Given this list of marker genes PLBD1, GPS1, MGAM (NCBI Gene Id 8972), BMPER, PGBD1, MYO16 (NCBI Gene Id 23026), PPP2R3A, KRTAP9-9, SIRT1, TNFSF12, SIPA1L2, PKHD1, ABCB5 (ATP binding cassette subfamily B member 5), MMP13, ARMC3, KRTAP3-3, MAGEH1, DCLK3 (NCBI Gene Id 85443), CRLF2, SETD5, PBDC1, SMCP, CDY2B, ANK2, SLC35F2, OR2F2, CRTC1, GNG2, CEP126, SEMA6D, CIMAP3, SCGB1C1, CIMAP1A, IRF2, MITF, FAM170A, ABCA13, NRXN3, WDR64, TMEM108, KRT20, RPE65 (NCBI Gene Id 6121), RFNG, RGS7BP, SPATA6, MINDY3, ARHGAP18, LRRN1, FOXN2, CYP2E1, ORAI2, CA1, FRMPD2, CALCR, CDY1, NSMF, RIT2, KCNK2, HERC2P9, SERPINB4, TRPM2, SNHG17, CCDC54, OR2F1, LIMCH1, ZPLD1, VCAN, ANGPTL5, CLNK, MS4A3, AMOTL1, SERPINB3, UPK1B, RARA, FAT3, CAPN13, LINC00907, RPL13AP17, DNASE2B, NRAP, POU6F2, SULT1C2, MAB21L4, CLIC1, ZDBF2, CDY1B, KLHL2, FYB1, CPQ, LPAR3, ELOVL7, RPL35P1, MEP1A, KRTAP13-1, ENOX1, OR6W1P, MLF1, NCALD, LINC03122, TNFSF12-TNFSF13, GALNT5, GTF3C2, AK5, OTULINL, HERC2P2, SPRR1A, KRTAP9-3, SAPCD1, PRB3, THEMIS, CLRN1, CACNB2, TNFSF13, MSH5 (NCBI Gene Id 4439), TMEM192, MME, TLR2, NAP1L2, LINC00994, INTU, EVA1C, NOVA1, IGSF11, LINC00305, CDY2A, KRT10, SLC9C1, ZC2HC1A, NEB, LTC4S, B3GNT2, IPCEF1, KCNMB2, LAMB4, VWDE, MAML2, EBF4, here is a description of the gene set: There is widespread interest in efficient characterization of differences between tumor and normal samples. Here, we show an effective methodology for genome-scale characterization of tumors. Using matched normal and tumor samples from liver cancer patients, as well as non-cancer-related normal liver tissue, we first determined changes in gene expression as monitored on RNA expression arrays. We identified several hundred mRNAs that were consistently changed in the tumor samples. To characterize the mechanisms responsible for creation of the tumor-specific transcriptome, we performed chromatin immunoprecipitation on microarray experiments to assay binding of RNA polymerase II, H3me3K27, and H3me3K9 and DNA methylation in 25,000 promoter regions. These experiments identified changes in active and silenced regions of the genome in the tumor cells. Finally, we used a virtual comparative genomic hybridization method to identify copy number alterations in the tumor samples. Through comparison of RNA polymerase II binding, chromatin structure, DNA methylation, and copy number changes, we suggest that the major contributor to creation of the liver tumor transcriptome was changes in gene copy number. Genes whose promoters display higher histone H3 trimethylation mark at K9 (H3K9me3) in hepatocellular carcinoma (HCC) compared to normal liver. from publication Acevedo LG, Bieda M, Green R, Farnham PJ (PMID 18413731) studied in species Homo sapiens Human Gene Set: ACEVEDO_LIVER_CANCER_WITH_H3K9ME3_UP